Given this list of marker genes SAA1, KRT6A, COL17A1, S100A2, CAV2, KRT5, EFNB1, AKR1C1, LMTK3, CSF2, TRIM29, PTGS2, FGFBP1, EIF2B3 (eukaryotic translation initiation factor 2B subunit gamma), BARX2, KRT14, S100A8, FXYD3, FASN, LGALS7, COL7A1, LAMA3, KRT15, KLK5, PTPRK, TM4SF1, PTHLH, PPP1R14C, LAMB3, KRT13, MRAP2 (melanocortin 2 receptor accessory protein 2), SPRR2C, B3GNT5, CDH3, DSP, ROPN1L, CYP26A1, ANXA8L1, MAOA, ALDH1A3, SERPINE1, SERPINB2, LAMC2 (laminin subunit gamma 2), GJB5, S100A9 (S100 calcium binding protein A9), F2RL1 (NCBI Gene Id 7901), LIPG, CLDN8, MMP14, SERPINB5, KRT1, CA2, TENM2, ITGB4, DSC3, GPX2, TP63, CXCL1, ITGA6, TFPI2, CSTA, PGAP4, AREG, ANGPTL4, KRT17, ADRB2, SPRR1B, GABRE (NCBI Gene Id 2564), FBN2, PI3, KRT6B, AKR1C3, DUSP6, KLHL13, CAV1, HAS3, CALML3, DMRT2, KLK10, DST, here is a description of the gene set: Genes in the cancer module 297. species: Homo sapiens Human Gene Set: MODULE_297